Given this list of marker genes ATXN7L1, DLC1, HOXB-AS3, C6orf58, BACH2, ZNF217, CNOT2, MLLT3, RFX3, RTN4R, SEMA6A, RERE, H4C16, ABITRAM, PITPNM2, PAPLN, PARK7, TBCD, NXN, MECOM, DLEU1, TMEM248, TTC5, ECD, CCDC192, SPRY2, ELP1, NCKAP5, LIMA1, ZNF460, RHOBTB1, LINC01392, CREM, PDCL3P6, ICAM4, DCP1A, HMGB1, GSK3B, WDR26, FOXM1, ATP2B4, BMPR1B, EXOSC10-AS1, SLC35A1, RDUR, ZNF131, KDM1A, TIPRL, INTS12 (integrator complex subunit 12), ENAH, SCRN1, TTC23, CREBBP, NFKB1, WDR62, SIPA1L3, MIR3650, FRMD4B, ALDH1A2, NSL1, ZDHHC12, MRPL27, GABPB2, TBCA, DSTN, KDM3A, LINC02609, RFX3-DT, TM7SF3, HSD17B12, PTPA, SLC2A9-AS1, HOTAIR, YBX3, CDK2AP1, CD4, FEM1C, ENSG00000227496, ASCC1, VCPKMT, ASPHD2, SUN1, EME1, TRIP4, DUSP6, FAM149B1, KCNK1, PCLAF, SLC38A2, ZDHHC12-DT, NACA4P, HBP1, HOXA5, TRMT1, MALAT1, TGIF1, BDNF, TMEM147-AS1, ARRDC3, BTN2A2, ENSG00000224865, ETNK1-DT, MTLN, GSK3B-DT, VTRNA1-2, DOCK7-DT (DOCK7 divergent transcript), TLK2, DNAJC6, CRTAP, GSTCD, SPPL3, MTCL3, TMEM147, MRTFA, TPX2, CCT6B, ZCCHC9, LIFR-AS1, RNU6-535P, ZNF608, CDC42SE1, F2RL1, ARID1A, CCDC66, LINC02172, EIF4G3 (NCBI Gene Id 8672), DRG2 (developmentally regulated GTP binding protein 2), HOXB3, MVB12B, MIR1273C, PDE4D, NSMCE2, VWA8, KAZN, CLIP1, NFATC2, BRF2, IFNAR2, TSPYL4, MED24, ENSG00000278356, RN7SL385P, CKMT2-AS1, TWF1P1, MYLK, SLC25A16 (solute carrier family 25 member 16), TATDN3, FARP1, MIR194-1, ITPRIP, BFSP1, here is a description of the gene set: species: Homo sapiens Human Gene Set: ZSCAN5C_TARGET_GENES from publication Yevshin I, Sharipov R, Kolmykov S, Kondrakhin Y, Kolpakov F (PMID 30445619)